The following is a description of a gene set: species: Mus musculus Any process that modulates the frequency, rate or extent of the hydrolysis of a peptide bond or bonds within a protein. Mouse Gene Set: GOBP_REGULATION_OF_PROTEOLYSIS, and this is the list of marker genes: Hsp90ab1, Dda1, Tm4sf20, Tdpoz1, Cpb2, Rbx1, Nedd8, Ube2v2, Myh9, Cyfip2, Cav1, Src, Ins2, Plat, Chac1, C2cd3, Aph1a, Rab23, Pabpn1l, Socs4, Usp13, Cop1, Inpp5b, Grn, Timp2, Smurf1, Pik3r1, Psme3, Dlgap1 (DLG associated protein 1), Caml, Egf, Ift52, Phf20l1, Hspa8, Spopl, Spock1, Rhbdf2, Rybp-ps, Tank, Ppp1r15a, Timp1, Cstdc6, Cbfa2t3, Trim67, Snx33, Ccbe1, Gabarap, Cdk5, Antxr1, Nfe2l1, Glg1, Prss37, Osbpl7, Tnfrsf1b, Fbxw11, Aph1b, Pbk, Tgfb1i1, Cldn3, Xbp1, Sgta, Wfs1, Rhbdf1, Ubqln4, Perp, Tmx1, Timp4, Stat3 (signal transducer and activator of transcription 3), Sh3d19, Xpo1, Fhit, Trem2, Mbp (myelin basic protein), N4bp1, Bak1, Wnt1, Pten, Tmtc3, Traf3, Ufsp2, Tdpoz8, Trib2, Plk3, Csta3, Sh3rf3, Plk2, Psenen, Serpinb13, Qrich2, Atp13a2, Foxf2 (forkhead box F2), Eppin, Cfl1, Pml, Serpinb1c, Laptm5, Axin2, Ide, Usp9x, Bad, Gas1, Serpinf2, Wnt10b, Serpine2, Tmem259, Nupr1, Tdpoz3, Tspan15, Sumo2, Styx-ps, Ctsc, Ecscr, Hspa1a, Wfdc6a, Cdkn2a, Ern1, Gapdhrt2, Lrrk2, Ifng, Cdk5rap3, Commd1, E330034G19Rik, Wfikkn1, Adam9, Mtm1, Csta2, Rgn, Rad23b (RAD23 homolog B, nucleotide excision repair protein), Rfx4, Serpinb7, Epm2a, Serpina5, Tspan17, Taf9, Ncstn, Timm17a, Traf7, Nkd2, Epha4, Csnk1d, Usp38, Hamp, Prickle1, Adra2a (adrenergic receptor, alpha 2a), Cdc20, Hipk2, Plgrkt, Ccdc22, Ptk2, Hspbp1, Rnf180, Atp5if1, App, Clec3b, Dvl1, Serpinb6d, Fbxw7, Serpinb10, Rybp, Il10, Klhl40, Furin, Zfand2a, Cstdc3, Fmr1, Notch4, Kng2, Styx, Ptk2b, S100a10, Aph1c, Sumo3, Serpinb6e, Aurka, Cd46 (CD46 antigen, complement regulatory protein), Gba1, Adam8, Sh3rf2, Anks1, Glmn (NCBI Gene Id 170823), Tnp1, Tmem67, Kng1, Eno1b, Stub1, Spink12, Park7, Ubqln1, Ift88, Clec16a, Mbl2, Rpl5, Serpinb1b, Psma3, Anxa2, Pkd1, Gsn, Cntn2, Cst3, Rnft2, Dnajb2, Ddrgk1, Sco1, Lrig2, Capn3, Trf, F8a, Serpinb9, Serpinb9d, Gsk3a, Ccar2, Oga, Spock3, Mdm2, Smarcc1, Rad23a, Atxn3, Apoe (apolipoprotein E), Marchf7, Zer1, Serpinb6a, Prmt6, Rgma, Chfr, Plau, Serpinb9h, Ctla2a, Araf, Ecm1, Ube3a, Ube2k, Psmf1, Atg7, Usp14, Tmem98 (transmembrane protein 98), Pias1, Il33 (NCBI Gene Id 77125), Gapdhrt, Tnf (tumor necrosis factor), Il1r2, Serpinb9e, Rhbdd1, Spon1, Timp3, Spink2, Ubxn2a, Pdcl3, Psen1, Sirt2, Gapdh, Tbc1d10a, Lamp3, Dnaaf4, Tmf1, Stfa2, Tdpoz5, Spop, Parl, Vtn, Aurkaip1, Reck, Vsir, Rpl11, Timm23, Gipc1, Fetub, Sufu, Nub1, Herpud1, Serpinb9b, Csnk2a2, Psme1, Fzr1, Bcap31, Cast, Stfa1, Pacsin3, Aqp11, Stfa3, Psen2, Prkaca, Mmp14, Sirt6, Crb2, Lats1, Plaur, Pabir1, Tdpoz2, Serpinb9f, Bin1, Fgfr4, Cdc20b, Spink6, Prkacb, Prkn, Tspan5, Ldlrad3, Svip, Usp5, Ubqln2, Agtpbp1, Gapdh-ps15, Ubb (ubiquitin B), Sh3rf1, Det1, Agbl4, Uchl5, Tmem168, Nop53, Csnk1e, Stfa2l1, Usp25, Psmd10 (proteasome (prosome, macropain) 26S subunit, non-ATPase, 10), Cldn4, Vcp, Sirt4, Pithd1, Gsk3b, Eif3h, Tdpoz4, Mapk9, L3mbtl3, Ttc36, Cstdc5 (cystatin domain containing 5), Serpinb8, Nlrc4, Btrc, Spink1, Cldn13 (claudin 13), Fbxw8, Senp1, Hdac6, Meltf, Prss22, Psme2, Ctnnd1, Psme3ip1, Zfp418, Ophn1, Asph, Nudt15, Rpl23 (ribosomal protein L23), Wac, Lyn, Mtor, Serpinb6b, Eif2ak3, Disc1 (NCBI Gene Id 640053), Ins1, Dab2ip, Trp53, Clu, Shh (sonic hedgehog), Prkcg, Zyg11b, Sumo1, Eno1 (enolase 1, alpha non-neuron), Astl, Snx12, Rps7, Gpld1, Gpx1, Tmed10, Hfe, Rchy1, Serpinb6c, Rack1, Ogt, Plk1, Ager, Rnf185, Usp17le, Usp7, Prelid1, Bag6, Psmb8, Gclc, Rbx1-ps, Ptpn3, F2, Hdac2, Ptpn1, Rcn3, Csnk2b, F12, Usp19, Trib3, Casp8, Tlk2, Ufl1, Angptl8, Nrdc, Usp26 (ubiquitin specific peptidase 26), Alad, Bag2, Ctsh, Gna12, Eif2a, Il1b, Ubxn1, Cstb, Paqr3, Efna3, Serpinb9c, Fuz, Thbs1, Akt1, Tdpoz9, Sfrp2, Rnf139, Socs5, Tnp2, Cln3, Acp4, Sirt1, Desi1, Rps6ka2, Serpine1, Psmd14, Hpn, Oaz1, Efna1, Nr1h3 (NCBI Gene Id 99182), Fadd, Rhobtb3, Trim39, Spopfm2, Gsap, Cst7, Dab2, Spopfm3, Ist1, Cwh43, Fbxo22, Nr1h2, Snx9, Cln6, Kcne2, Mapk8, Gabarapl2, Trib1, Serpinb9g, Map1a, Hspa1b, Rnf40, Rnft1, Bag5, Csta1, Cstdc4, Cdh1 (NCBI Gene Id 12550), Csnk1a1, Ctsz, Bbs7, Trim32, Svbp, Spink5, Serpinb1a, Axin1, Ep300